The following is a description of a gene set: Mouse Gene Set: GOBP_PROTEIN_NITROSYLATION species: Mus musculus The covalent addition of a nitric oxide group to an amino acid within a protein., and this is the list of marker genes: Gapdh, Snta1, S100a8, Nos1, Txn1, Nos2, Ncoa7, Adh5, S100a9, Tbc1d24, Ddah1, Oxr1